Given this list of marker genes Calb1, Vdr, Cyp2r1, Gc, S100g, Comp, Bspry, here is a description of the gene set: Mouse Gene Set: GOMF_VITAMIN_D_BINDING Binding to vitamin D, any of a group of related, fat-soluble compounds that are derived from delta-5,7 steroids and play a central role in calcium metabolism. Specific forms of vitamin D include calciferol (ergocalciferol; vitamin D2) and cholecalciferol (calciol; vitamin D3). studied in species Mus musculus